Given this list of marker genes UGT1A6, GSR, MT1X, TXN2 (NCBI Gene Id 25828), SOD3, CYP1A1, MGST1, NOX3, XDH, NQO1, TXNRD1, MAPK14, SOD2, CAT, FOS, NFKB1, CYBB, GSTT2, NOX5, NOX1, MAOA, NFIX, NFE2L2 (NFE2 like bZIP transcription factor 2), GCLC, HMOX1, JUNB, GPX3, TXNRD2, NOX4, MAPK10, SOD1 (NCBI Gene Id 6647), GPX1, SP1, here is a description of the gene set: Human Gene Set: WP_OXIDATIVE_STRESS_RESPONSE Oxidative stress response studied in species Homo sapiens